The following is a description of a gene set: Human Gene Set: HP_AMBIGUOUS_GENITALIA_MALE Ambiguous genitalia, male studied in species Homo sapiens Ambiguous genitalia in an individual with XY genetic gender., and this is the list of marker genes: TSPYL1, SC5D, SRY, TBX15, SRD5A2, MKS1, CYP11A1, DHCR24, HSD3B2, CYB5A, WT1, CYP17A1